Given this list of marker genes BTG1, ZBTB43, FCMR, GCNT1 (glucosaminyl (N-acetyl) transferase 1), DMPK, POU4F1, ZBTB14, GPR137B, C6orf118, TNFRSF13C, LRRCC1, SFI1, MCUR1, JDP2, INVS (NCBI Gene Id 8014), CECR2, TNRC6C, RASSF4, USP7, RDH12, EPC1 (enhancer of polycomb homolog 1), TASOR, HAAO, CDC14A, METTL14 (methyltransferase 14, N6-adenosine-methyltransferase non-catalytic subunit), LPGAT1, KIF1C, LYN, BACH2, TMEM131L, PITPNC1, USP25, ZNF18, PITPNM2, H2AZ1, LHFPL4, CELSR1, TSGA10, TUBA1A, NEURL2, CIBAR1, VRK2, BLVRB, PRXL2A, LTB, CPNE5, REV3L, TRNAU1AP, SCAF4, FOXO1, RNF157, ATP8A1, CNTLN, EXO5, USF2, ETS1, OXSR1 (oxidative stress responsive kinase 1), SPIB, ZNF839, DCUN1D1, BBS4, NCOA1, CISD2, MPRIP, BCL2A1, GIT2, PHF13, NUAK2, MARVELD2, B9D2, ITGA3, FH, CASP9, TGFBR2, SLC25A40, LY86, VEZF1, STAU2 (staufen double-stranded RNA binding protein 2), MCTP2, TRIP13 (NCBI Gene Id 9319), CNN2, GGA3, ITPRIP, BORCS7 (NCBI Gene Id 119032), CENATAC, BMPR1A, LRCH1, PI4KB, IGF2BP3, ICAM1, TREML2, ANP32A, GOPC, HPSE, EIF2AK4, GMIP, ZC3H12D, VOPP1, SLC44A2, SIPA1L1, CD22, CKS2, GKAP1, C2orf76, TMEM63A, MIF4GD, PAN3, CAMTA1, IFT57, S1PR2, COLCA1, SLFN13, MIDEAS, ATE1, GRAMD4, PDIK1L, NFATC2IP, OXA1L, ATXN7L1, RCSD1, WDPCP, APOE, CDK5RAP1, HPF1, CORO1C, COX6A1, OTUD1 (NCBI Gene Id 220213), OTUB2, PNP, HMGN3 (NCBI Gene Id 9324), SMAGP, RP9, CDCA5, FBXO34, UBE2R2, IKZF3, IRAK1BP1, LMO7, ACKR2 (NCBI Gene Id 95073), CDKL1, ZBED3, ZBTB25, BTBD8, CDK13, STXBP1, ANO3, ELK3, MCM6, PANK2, NCF1, KIAA0930, KLHL14, ZNF148, MRPL41, TAMM41, ADHFE1, ARHGAP17, FKBP5, ARIH2, PARP8, C8orf58, PRKCB, VAV2, SIGIRR, MYOT, HSPA8, IFNGR1, STARD9, SH3BGRL2, PTPRJ, C8A, DCP2, GXYLT1, MXD3, ANKFY1, BMP2K, FGD6, GAR1, OPTN, BTLA, STK10, MTA3, BLK, OXLD1, DTX1, PLEKHA2, GSN, CDC42EP3, ZBTB9, PTK2, TBC1D5, CARD11, ASB13, LRRC75A, INPP5F, FYCO1, CEP162 (NCBI Gene Id 22832), MAP7, ABHD6, TMEM131, here is a description of the gene set: Genes down-regulated in T reg: IKZF4 versus wildtype. Human Gene Set: GSE40273_EOS_KO_VS_WT_TREG_DN from publication Fu W, Ergun A, Lu T, Hill JA, Haxhinasto S, Fassett MS, Gazit R, Adoro S, Glimcher L, Chan S, Kastner P, Rossi D, Collins JJ, Mathis D, Benoist C (PMID 22961053) The transcription factor FoxP3 partakes dominantly in the specification and function of FoxP3+ CD4+ T regulatory cells (Tregs), but is neither strictly necessary nor sufficient to determine the characteristic Treg transcriptional signature. Computational network inference and experimental testing assessed the contribution of several other transcription factors (TFs). Enforced expression of Helios or Xbp1 elicited specific signatures, but Eos, Irf4, Satb1, Lef1 and Gata1 elicited exactly the same outcome, synergizing with FoxP3 to activate most of the Treg signature, including key TFs, and enhancing FoxP3 occupancy at its genomic targets. Conversely, the Treg signature was robust to inactivation of any single cofactor. A redundant genetic switch thus locks-in the Treg phenotype, a model which accounts for several aspects of Treg physiology, differentiation and stability. species: Homo sapiens